The following is a description of a gene set: studied in species Mus musculus The mitotic divisions of the primary spermatogonial cell (a primordial male germ cell) to form secondary spermatogonia (primary spermatocytes). Mouse Gene Set: GOBP_SPERMATOGONIAL_CELL_DIVISION, and this is the list of marker genes: Ythdf2, Tle6, H3f4, Brip1 (NCBI Gene Id 73108), Dicer1, Zfp449